The following is a description of a gene set: Human Gene Set: GOBP_REGULATION_OF_DNA_BINDING_TRANSCRIPTION_FACTOR_ACTIVITY species: Homo sapiens Any process that modulates the frequency, rate or extent of the activity of a transcription factor, any factor involved in the initiation or regulation of transcription., and this is the list of marker genes: PARP10, ADCY8, TFDP1, CD40LG, BCL3, ANXA3, TFDP3, FLNA, RPS3, ARRB1, TRIM22, RAB7B, RPS6KA5, MEN1, CRNN, ZNF431, RHEBL1, NLRC4, SIRT1 (sirtuin 1), S100A8, NLRP3, NLRC3, PHB2, KIT, HAVCR2, NLRC5, TRIM31, DHX9, SYK, NR0B2, RIPK1, CEBPG, ERC1, PPIA, TRIM34, DDR2, RTKN2, RIPK3 (NCBI Gene Id 11035), ESR1, TNF, TRIM27, TSSK4, CRTC1, TRIM8, CYP1B1, CARD16, ZBTB7A, NUPR1, KDM5A, RPS6KA4, NWD1, TRIM25, ARID5B, S100A9, PRMT2, TRIM52, TNFSF18, ARHGEF2, TRIM15, HCK, LRRC14, PYDC1, EPHA5, CREBZF, NEUROD1, ADCY1, TLR2, MAP3K10, PRDX3, TRAF6, TRIM21, ID1, RELA, DHX33, LGALS9, NEUROD2, PRKD2, MID2, UBE2N, IKBKB, PBX1, CLOCK, CRTC2, NEUROG1, SIK1, IRAK1, TRIM32, PSMD10, CARD11 (caspase recruitment domain family member 11), TERF2IP, SPHK1, STING1, SETD6, COPS5, IKBKG, TRIM37, AGER, OTULIN, ARRB2, RNF25, HSPA1A, IL18RAP, PRKD1, ACOD1 (aconitate decarboxylase 1), PIM1, CDK5RAP3, CYLD, ID3, TRAF5, ATF2, FANK1, CARD14, CIB1, ZC4H2, ARHGEF5, PIAS2, SUMO1, FOXP3, TRIM13, RNF31, BTK, CAMK1D, C8orf44-SGK3, RBCK1, MTPN, TMIGD3, FER, TCF3, BRMS1, ADGRG3, TRIM26 (NCBI Gene Id 7726), NLRP2B, PYCARD, TCEAL7, RNF2, NPM1, FOXS1, NEUROG2, RIPK4, SGK1, RWDD3, PRKCI, CARD9, DDRGK1, POU4F1, PKHD1, CACTIN (cactin, spliceosome C complex subunit), POU4F2, COMMD1, RNF220, NFKBIA, PYDC2, CMKLR1, EP300, USP7 (ubiquitin specific peptidase 7), GFI1, ADORA3 (NCBI Gene Id 140), PRKCH, CHUK, ESR2, AIM2, STK36, PRKCZ, LTF, ZIC2, IL18R1, S100A12, PEX14, TRIM62, NOD1 (nucleotide binding oligomerization domain containing 1), TRIM14, ROR1, SRF, PRKCQ, IL18, UFL1, CLU, MAP3K13, ALK, BCL10, RB1, NTRK1, FOXA1 (forkhead box A1), MTDH, CAMK2A, TRAF1, NOD2, CHP1, C14orf39, SGK3, HEYL, TRIM38, DDIT3 (NCBI Gene Id 92982), TRIM5, TRAF2, MTURN, PAXIP1, ERBIN, EIF2AK2, COMMD6, TRIM40, EIF2AK4, COMMD7, HSPA1B, ID2, C3orf33, MYD88, TLR4, SYT14P1, NFKBIL1, ENPP1, TRAF3